The following is a description of a gene set: Human Gene Set: GOBP_TRANSCRIPTION_ELONGATION_BY_RNA_POLYMERASE_I studied in species Homo sapiens The extension of an RNA molecule after transcription initiation and promoter clearance at an RNA polymerase I specific promoter by the addition of ribonucleotides catalyzed by RNA polymerase I., and this is the list of marker genes: GTF2H5, POLR1E, POLR1F, POLR1D, ERCC6 (NCBI Gene Id 282965), POLR2E, ERCC2